The following is a description of a gene set: Mouse Gene Set: CUI_CDC2_IL7_RESPONSE_DN Genes negatively differentially expressed in cell type: cDC2 (conventional dendritic cell type 2) upon treatment with cytokine: IL-7 in mouse lymph nodes in vivo. species: Mus musculus from publication Cui A, Huang T, Li S, Ma A, Pérez JL, Sander C, Keskin DB, Wu CJ, Fraenkel E, Hacohen N (PMID 38057668) Cytokines mediate cell-cell communication in the immune system and represent important therapeutic targets. A myriad of studies have highlighted their central role in immune function, yet we lack a global view of the cellular responses of each immune cell type to each cytokine. To address this gap, the authors created the Immune Dictionary, a compendium of single-cell transcriptomic profiles of more than 17 immune cell types in response to each of 86 cytokines (>1,400 cytokine-cell type combinations) in mouse lymph nodes in vivo. A cytokine-centric view of the dictionary revealed that most cytokines induce highly cell-type-specific responses. For example, the inflammatory cytokine interleukin-1β induces distinct gene programmes in almost every cell type. A cell-type-centric view of the dictionary identified more than 66 cytokine-driven cellular polarization states across immune cell types, including previously uncharacterized states such as an interleukin-18-induced polyfunctional natural killer cell state., and this is the list of marker genes: Tbc1d9, Pold4, Acadm, Pdcd4, Arhgap15, Kit, Il6st, Ppm1k, Eef2, Dusp1, Zfp36l2, Brd3, Mbnl1, Gdi2, Fos, Stk38 (serine/threonine kinase 38), Fosb, Txnip, Btg2, Fau, Itgb7, Ffar4, Borcs6, Klhl24, Tent5a, Kctd12, Hspa1a, Klf4, Pgap1, Ramp1, Myo5a, Hspa1b, Deptor, Sesn3, Ctdsp2, Pfkfb3, Klrd1, Mef2c, Tut4, Foxp1, Nsa2 (NSA2 ribosome biogenesis homolog), Bnip3l, Ankrd44, Tsc22d3, B4galt6, Flt3, Pid1, Mier1, Ypel3, Cox7a2l, Fbrsl1, Stard9, Klf2, Jun, Mxd4, Emb, Add3, Trappc5, Aph1c, St8sia4